The following is a description of a gene set: studied in species Homo sapiens Genes having at least one occurrence of the motif GNNTTGTTTACNTT in the regions spanning 4 kb centered on their transcription starting sites. This matches the FOXO1A transcription factor binding site V$FOXO1_02 (v7.4 TRANSFAC). Human Gene Set: FOXO1_02, and this is the list of marker genes: NR1D1, UTY, TSC22D3, IL6ST, HOXB8, GFI1B, ACKR4, CLC, FOSL2, HOXA2, DHRS3, GNAO1, ETV5, FOXP2, SH2D4A, ABCA6, NAA15, NDUFA5, HOXC11, HBP1, KMT2E, TRERF1, XPO7, CLEC4D, CFL2, MRGPRF, FRY, MOBP, RBM39, H3-3A, DDIT4, MARCKSL1, FGF10, LIX1L, NRN1L, TEK, ART3, GRB7, GPR174, PAK1, DIXDC1, PTS, KRT85, AZI2 (NCBI Gene Id 64343), DLL1, IKZF4, STK35, SIAH3, DDX5, MDK, ZBTB9, PURA, SATB2, BRD8, SLU7, GNAS, LIMK2, TMEM50A, SEMA6D, PHF21A, CDKN1C, ITGB8, EIF4EBP2, CAMK2G, MEIS2, STX6, SLC25A39, PIK3C2A, TSHZ3, MLLT6, TSPAN13, TMPRSS15, VSIG2, CLPX, RAD21, AKT1S1, PPM1B, HNRNPA0, AAMDC, PAGR1, ASXL1, EML1, NDRG1, TBCC, NKX2-2, TFAP4, ULK1, PELI2, LSM14A, HLX, TNRC6A, HNF1A, STOML3, HEBP2, CELF6, AKT2, GRAP2 (NCBI Gene Id 9402), THRA, CLSTN1, DDX46, CREBRF, SELENOP, EN2, IL1RAPL1, RSF1 (NCBI Gene Id 51773), PITPNC1, KIF20A, DENND2B, SRSF1, PTGR3, PDGFA, CHCHD7, EZH1, ZMAT4, KLF9, SMAD5, KLF12, NFIB, PNPLA2, PIK3IP1, MAP4K5, HOXA1, OSBPL5, ROGDI, KCNJ16, MAPK10, PROX1, MSMB (NCBI Gene Id 4477), CNNM3, EPHB2, CREBL2, SH3RF1, WDR46, MBTPS1, SALL3, NUB1, TRIM63, TSSK2, KCNJ5, PITX2, FOXG1, NRG1, CLIP2, ZBTB18, JAG1, SLC38A3, SIN3A, HOXA11, PSEN1, PRDM1, HOXB4, PCDH18 (NCBI Gene Id 54510), GCNT2, IGSF21, INSIG1, JPH3, NEDD4, IRX4, CDKN1A, ID2, TXNDC12, ETV1, NR2F1, DBNDD2, SERTAD4, CSRNP3 (NCBI Gene Id 80034), DNAJB12, JADE2, CACNA2D1, RASD2, MTX1 (metaxin 1), CHD2 (NCBI Gene Id 283680), FOXN3, SKIDA1, RFX1, LEMD1, HTN1, LAMC2, ROR1, TGFB3, DTNA, ASTN1, MDGA1, SLC10A7, KCNA1, HOXA10, PHOX2B, TENM1, EIF4G1, FOXO1 (forkhead box O1), MITF, HR, NTN1, CFAP161, ANKRD28, HSH2D, TET2, PLEKHA5, SCRN3, RASD1, CD109, ERG, MAFF, LMO4, SH3GL3, TBX4, YTHDC1, SERINC3, CCDC89, ARID4A, C12orf50, WNT2B, TRIM8, TBC1D17, BMP2, PTCH1, PFDN6, C1orf43, OTUD7B, FAM53C, TBL1X, CADM1, WBP2NL, C1QTNF3, RORA, THBS3, EHD1, ZNF711, HOXC8, LHX9, PI4K2A, SREK1, TMEM71, TCF15, CEP95, SNCAIP, KDM6A, MMP13, POU2F1, PTMS, LIFR, FGF9, STX16, SQSTM1, NFIX, CSNK1G3, TCF7, PLAG1, FSTL1